Given this list of marker genes Ankrd31, Top6bl, Iho1, Mre11a, Mei4, Rec114, Spo11, Hormad1, here is a description of the gene set: The cell cycle process in which double-strand breaks are generated at defined hotspots throughout the genome during meiosis I. This results in the initiation of meiotic recombination. studied in species Mus musculus Mouse Gene Set: GOBP_MEIOTIC_DNA_DOUBLE_STRAND_BREAK_FORMATION